The following is a description of a gene set: species: Homo sapiens Binding to a protein upon poly-ubiquitination of the target protein. Human Gene Set: GOMF_POLYUBIQUITIN_MODIFICATION_DEPENDENT_PROTEIN_BINDING, and this is the list of marker genes: UBQLN1, OTUD7A, UBAC1, MINDY2, RNF168, UBQLN2, TAB2, BAG6, BABAM2, EPS15, RAD23B, BRCC3, RAD23A, VCP, ASCC2, HDAC6 (NCBI Gene Id 100820762), SQSTM1, IKBKE, AGL, UBL7, UBQLN3, UBXN1, DZIP3, PARP10, AFG2B, ZBTB1, TNIP3, UBQLNL, RAD18, TOM1 (NCBI Gene Id 10043), ZFAND2B, MPND, IKBKG, ZRANB3, NPLOC4, MINDY1, UBQLN4, TAB3, ATRIP, PSMD4, WDR81, FAAP20, AGAP3, ABRAXAS2, OTUD7B, PRPF8, RNF169, SHARPIN, DNAJB2, UFD1, TNFAIP3, ZFAND6, TNIP2, OPTN, ZRANB1, SPRTN, RNF31, UIMC1, ABRAXAS1